The following is a description of a gene set: Mouse Gene Set: CUI_T_CELL_CD8_IFNE_RESPONSE_DN from publication Cui A, Huang T, Li S, Ma A, Pérez JL, Sander C, Keskin DB, Wu CJ, Fraenkel E, Hacohen N (PMID 38057668) species: Mus musculus Genes negatively differentially expressed in cell type: CD8+ T cell upon treatment with cytokine: IFN-ε in mouse lymph nodes in vivo. Cytokines mediate cell-cell communication in the immune system and represent important therapeutic targets. A myriad of studies have highlighted their central role in immune function, yet we lack a global view of the cellular responses of each immune cell type to each cytokine. To address this gap, the authors created the Immune Dictionary, a compendium of single-cell transcriptomic profiles of more than 17 immune cell types in response to each of 86 cytokines (>1,400 cytokine-cell type combinations) in mouse lymph nodes in vivo. A cytokine-centric view of the dictionary revealed that most cytokines induce highly cell-type-specific responses. For example, the inflammatory cytokine interleukin-1β induces distinct gene programmes in almost every cell type. A cell-type-centric view of the dictionary identified more than 66 cytokine-driven cellular polarization states across immune cell types, including previously uncharacterized states such as an interleukin-18-induced polyfunctional natural killer cell state., and this is the list of marker genes: Fos, Uba52, Hspa1a, Hspa1b, Tsc22d3, Jun, Klf6